The following is a description of a gene set: The series of molecular signals generated as a consequence of activation of the transmembrane protein Smoothened contributing to the dorsal/ventral pattern of the neural tube. Human Gene Set: GOBP_SMOOTHENED_SIGNALING_PATHWAY_INVOLVED_IN_DORSAL_VENTRAL_NEURAL_TUBE_PATTERNING studied in species Homo sapiens, and this is the list of marker genes: GPR161, TULP3, TBC1D32, GLI3, WDR19